The following is a description of a gene set: Mouse Gene Set: GOBP_SNRNA_TRANSCRIPTION The synthesis of small nuclear RNA (snRNA) from a DNA template. species: Mus musculus, and this is the list of marker genes: Rpap2, Snapc2, Ell3, Ell2, Snapc3, Ell, Myod1, Larp7, Snapc4, Ice2, Larp7-ps, Snapc1, Polr3b (NCBI Gene Id 97660), Cc2d1a, Zc3h8, Snapc5, Uspl1, Mepce, Ice1